The following is a description of a gene set: The transcription factor Foxp3 is usually considered the master regulator for the CD4+CD25+ Genes down-regulated in comparsion of WTActCD4 versus WTActCD4TGF (see Fig. 1 in the paper for details). Human Gene Set: GSE7460_CTRL_VS_TGFB_TREATED_ACT_FOXP3_HET_TCONV_DN from publication Hill JA, Feuerer M, Tash K, Haxhinasto S, Perez J, Melamed R, Mathis D, Benoist C (PMID 18024188) species: Homo sapiens, and this is the list of marker genes: SFXN3, NBEAL1, STAP2, IL17RD, CHD6, C19orf12, C12orf57, ID3, TLR2, MAVS, THY1, TSPAN32, LFNG (NCBI Gene Id 3955), AQP3, TRAF6, UBASH3B, KCTD11, SYTL1, PIGH, ANKRD50, FOXP3, TBC1D5, CYBA, YPEL3, IGFLR1, CCDC28A, RDH10, EMP1, TGIF1, SESTD1 (SEC14 and spectrin domain containing 1), LDLRAP1, RUNX3 (NCBI Gene Id 864), PIK3R1, CDH1, DNAH7, TBCB, GOLM1, ZNF827, COMMD7, CERK, AIRN, BCL9L, TNFRSF25, NTN4, ARHGAP9, SPRY1, LDLRAD4, CALCOCO1, UBXN6, NIPAL3, MIDEAS, IL18R1, CXXC5, FCRL1, PACSIN1, DCAF8, PYCARD, AAMDC, GPT, RAMP1, DBP, NECTIN2, ZBTB18, UCK1, CD37, FNBP1L, B9D2, SLX4IP, CD38, SULF2, MYL12B, ANTKMT, PLEKHM3, ATP6V1C2, SGIP1, TSPO, ABHD6, NDEL1, RINL, TRPC4AP, RRAS, CRLF2, DHRS3, KIF7 (NCBI Gene Id 46), CTSC (NCBI Gene Id 50958), SENP7, ITGAE, CD40, SUN2, WASHC2A, CHRM1, PROCR, WBP1, H19, ACAP1 (NCBI Gene Id 9744), ANXA3, ADCK5, JKAMP, MPHOSPH8, KLHL2, NRIP1, GCH1, NRARP, PIPOX, CNP, ADH1C, SNORD89, GPHN, DIAPH2, IRAK4, SGK1, XRN1, TPT1, BTG1, PLEKHD1, TNFRSF13B, CD52, CD3E, MMP11, FOXP1, NMT2, GPKOW, GSK3B, RNF149, TNFRSF13C, TPRG1L, SRPK2, COX7A2L, RNASE4, NCF4, CAMK2N1, ZBTB20, PREPL, CCPG1, CD151, EIF3F, RPLP0, LRIG1, SUOX (sulfite oxidase), F2RL1, ZNF839, CAPG, TBC1D16, GNB2, ACAA2, SBK1, IFT88, ATP1B1, GPR68, FBLN2, TNFSF11, NUDT14, PIH1D1, GABARAP, UBLCP1, MBD5, VPS37A, RABEP2, MFAP5, SPTAN1, CCS, TEN1, ADAMTS6, NRP1, APOBEC1, CD8A (NCBI Gene Id 925), ATP6V1G2, TTC33, TNFSF10, CUX1 (cut like homeobox 1), LIPA, CTSW, IKZF4, NT5E, PBXIP1, KCNF1, FOXO1 (forkhead box O1), HOXB7, USP6NL, NBDY, SKIL (SKI like proto-oncogene), KATNIP, CNKSR3, DNTTIP1, RNF167, EPC2, RNF135, TTC39B, TOR1AIP1, NCF1 (NCBI Gene Id 653844), RAB11FIP2, PIGP, ARRB2, TFAP2A, TTYH3, MMD, SIPA1, IL17A, METTL15, PRKCA (NCBI Gene Id 5578)